Given this list of marker genes Heph, Stk33, Bsn, Col5a1, Prkca, Smim18, Dcun1d4, Fyttd1, Stmn4, Ptcd1, Nptxr, Jade3, Garin5b, Shh (NCBI Gene Id 20423), Sp100, Rilpl2, Pum2, Gin1, Plekha6, Ppme1, Wdr5, Inhbb, Retreg3, Rnf41, Tfap4, Trim39, Rgs4, Rspry1, Cd200, A1cf, Tmem184b, Tacr3, Pcdh7, Rmnd1, Gpc6, Smurf2, Senp6, Slc38a2 (NCBI Gene Id 67760), Ncs1, Acacb, Ntng1, Lmtk2, Pou2f2, Stx3, Tsc1, Son (Son DNA binding protein), Synpo2l, Tia1, Gprin1, Sntb2, Tmem178b, S1pr1, Sdc3, Ccl22, Dcp1b, F2rl3, Ttc5, Arb2a, Mindy4, Rhog, Sorcs1, Igf1, Il17rd (interleukin 17 receptor D), Coq8a, Qki, Hadh, Faim2, Pdss2, here is a description of the gene set: Genes predicted to be targets of miRBase v22 microRNA mmu_miR_6930_3p in miRDB v6.0 with MirTarget v4 prediction scores > 80 (high confidence targets). studied in species Mus musculus from publication Chen Y, Wang X (PMID 31504780) Mouse Gene Set: MIR_6930_3P